Given this list of marker genes AMELX, TGFB1, FAM20A, SLC24A4, FAM20C, ROGDI, AMELY, MSX2, NECTIN1, CNNM4, CFTR, TBX1, TCIRG1, SLC4A2, MMP20, PPARA, ODAPH, ITGB6, STIM1, DMP1, AMTN, ENAM, here is a description of the gene set: species: Homo sapiens The process in which calcium salts, mainly carbonated hydroxyapatite, are deposited in tooth enamel. Human Gene Set: GOBP_ENAMEL_MINERALIZATION